The following is a description of a gene set: studied in species Homo sapiens Human Gene Set: GOBP_DOLICHYL_DIPHOSPHATE_BIOSYNTHETIC_PROCESS The chemical reactions and pathways resulting in the formation of dolichyl diphosphate, a diphosphorylated dolichol derivative., and this is the list of marker genes: DOLK, DOLPP1 (NCBI Gene Id 89888), DHDDS, SRD5A3, NUS1